Given this list of marker genes RGS4 (NCBI Gene Id 5999), SYNM, ZNF333, CUX2, C3orf18 (chromosome 3 open reading frame 18), PPP1R17, FANCC, ASIC1, GRID1, SPRY3, COL14A1, PBK, IL10, DENND4A, H2AZ1, KMT5B, COL5A2, RBBP9, PSMB4, XYLT1, AFF4, GNA12, SOX11, BLZF1, KIF13B, EFNA3, PIWIL1, PROSER1, SLC26A9, RBBP5, FZD3, RGS16, AFAP1L2, C10orf67, TSEN34, CSNK1A1 (NCBI Gene Id 55416), SMPX, WDR7, OXTR, TMPO, PHF21A, CDC42EP3, IRX2, SPRYD3, KLF10, SCRIB, CTCF (NCBI Gene Id 10664), RND1, COL11A1, BZW2, IL1A, GLO1, CD9, SLAIN1, CDK15, SF3B1, TCIM, STEAP1B, here is a description of the gene set: species: Homo sapiens Human Gene Set: MIR5007_5P Genes predicted to be targets of miRBase v22 microRNA hsa-miR-5007-5p in miRDB v6.0 with MirTarget v4 prediction scores > 80 (high confidence targets). from publication Chen Y, Wang X (PMID 31504780)